Given this list of marker genes Atp12a, Prkacb, Smg1, Sytl2, Slc25a3, Zfp975, Hdgf, Amigo1, Dnah5, Pgap1, Jade1, Dars1, Aak1, Ufl1, Fgd6, Tmem196, Lcorl, Tmprss11a, Plxna2, Unc5c, Cenpq, Picalm, Ddah1, Napg, Gpm6b, Cdc14b, Erbb4, Sp4, Slc35f1, Usp15, Auh, Mzt1, Rpe, Car14, Sdhc, C8b, Lsamp, Cstf2, Cdyl2, Ambn, Mon2, Bfar, S1pr5, Adarb1, Rfxap, Lrrc4c, Lypd1, Gtf2b, Vps13b, Paxip1, Vps26a, Epc2, Ppm1e, Strn3, Nfat5, Dscam, Vamp3, Bin3, Csad, Khdrbs2, Chmp1b, Nyap2, Six4, Zfp719, Cd109, Retreg1, Slc6a14, Sav1, Hira, Ascc3, Tmem167, Ifnar2, Cdk6 (cyclin dependent kinase 6), Spag9, Tent4b, Zfand5, Nadk2, Esyt2, Rsph4a, Acsm4, Zc2hc1a, Ttc14, Cenpw, Hsf2bp, Hoxd11, Nfe2l1, Ifi204, Armc8, Zfp629, Smad9, Asap2, Scai, Chmp5, Sel1l3, Mfsd14b, Ppm1l, Dclk1, Zdhhc21, Macir, Stxbp5l, here is a description of the gene set: Mouse Gene Set: MIR_384_3P Genes predicted to be targets of miRBase v22 microRNA mmu_miR_384_3p in miRDB v6.0 with MirTarget v4 prediction scores > 80 (high confidence targets). from publication Chen Y, Wang X (PMID 31504780) species: Mus musculus